Given this list of marker genes ENTPD6, TAF1A, ALG2, TLN2, PECAM1, ICE1, EPPK1, FEZ2, USP19, KANSL2, CYP2E1, ELL, FAM120AOS, IER5, PARP8, CBX4, CPNE7, ZNF263, MLH1 (mutL homolog 1), INPP5B, SLC26A11, TRAF1, TOB2, KBTBD11, PIANP, ARHGEF4, NEURL4, PIM2, MTFR1L, CDH1, UVSSA, SLC9A9, PLP1, IGSF8, PPFIA1, PLXNB2, SGSH (N-sulfoglucosamine sulfohydrolase), EDRF1, PRKCE, CARD6, FOXJ2, TAB2, ZNF623, NR1D2, CLCN6, RNF213, ZSWIM7, OTUD1, TTLL11, BRF1, SOCS7, MNX1, C1orf131, PGS1 (NCBI Gene Id 9489), ZDHHC3, RAB37, CRIM1 (NCBI Gene Id 51232), TNFRSF25, MGRN1, BEND3, POU6F1, PER3, COQ2, RBMS2, DHX33, IKBKE (NCBI Gene Id 9641), CUL9, RTP3, DNAJB2, PHF1, CAMKK1, PIK3R2, SEMA4A, SLC30A1, BRWD1, UBR5, DOLK, ARHGAP31, PPP1R13B (protein phosphatase 1 regulatory subunit 13B), KCNJ8, STAR, RREB1, FARP2, LPIN1, PHF21A, ZNF76, DDX60, DCAF8, ZNF217, UBA7, DBP, SBSN, AMIGO1, PDE4DIP, ZBTB7A, LRIG2, DMRTA1, C19orf48P, JMY, SEC16A, PPCDC, MIGA2, HDAC11, RIGI, CRTAM, ZBTB26, ADCK1, SFI1, RAPGEF2, BTG1, SLC20A1, CASP9, MAN2C1, KMT2C, NSUN4, PLEKHM3, IL7R, SLC35E3, DANCR, HS6ST1, METTL22, PFN2, XCL1, ZNF746, ARRB1, MICALL1, OSM, ZNF318, NMNAT3, DYRK2 (dual specificity tyrosine phosphorylation regulated kinase 2), P2RX4, GUF1, GSDMD, QPRT, ZBTB4, BCL11B, FCGR2B, DGKE, TRMT1, NPEPL1, DDB2, ZCCHC24 (zinc finger CCHC-type containing 24), BCOR, APOBR, ABTB3, LPP-AS2, AIRIM, TCN2, MDN1, TEF, RAB6B, PIK3IP1, GTF3C1, PRAMEF25, JADE2, FAM86B2, ZSCAN26 (NCBI Gene Id 7741), KIF3B, CBX7, GRWD1, HLA-E, SIPA1L3, FBXW4, RPL12, SEMA4B, PANK4, ENDOG, ARF3 (NCBI Gene Id 377), SF3B3, PRSS12, MBOAT7, DVL1, NR4A3, EEF1G, IFT172, AGO1, FBXL17, ZBTB18, RFLNB, BRAP, CYP17A1, SPOUT1 (SPOUT domain containing methyltransferase 1), SUSD2, BBS2, CREBRF, ZNF827, CZIB, FYCO1, NPFF, SGSM2, MAP3K14, JARID2, LEAP2, PRKCA, EHD3, TM6SF1, RERE, ARFRP1 (NCBI Gene Id 149661), TCAIM, PTCH1, here is a description of the gene set: CD8 T cells play a crucial role in immunity to infection and cancer. They are maintained in constant numbers, but upon stimulation with antigen undergo a developmental program characterized by distinct phases encompassing the expansion and then contraction of antigen-specific populations, followed by the persistence of long-lived memory cells. Although this predictable pattern of a CD8 T cell response is well established, the underlying cellular mechanisms regulating the transition to memory remain undefined. Here we show that TRAF6, an adapter protein in the TNF-receptor (TNFR) and IL-1R/TLR superfamily, regulates CD8 T cell memory development following infection by modulating fatty acid metabolism. We show that mice with a T cell-specific deletion of TRAF6 mount robust primary CD8 T cell effector responses, but have a profound defect in their ability to generate memory. This defect is CD8 T cell intrinsic and is characterized by the disappearance of antigen-specific cells in the weeks following primary immunization. Microarray analyses revealed that TRAF6-deficient CD8 T cells from early timepoints following immunization exhibit altered expression of genes that regulate fatty acid metabolism. Consistent with this, activated CD8 T cells lacking TRAF6 are unable to upregulate mitochondrial β-oxidation in response to growth factor withdrawal in vitro. Treatment with drugs that induce fatty acid oxidation enabled CD8 T cell memory generation in the absence of TRAF6. Remarkably, these treatments also increased CD8 T cell memory in wild type mice, and consequently were able to significantly improve the efficacy of an experimental anti-cancer vaccine. from publication Pearce EL, Walsh MC, Cejas PJ, Harms GM, Shen H, Wang LS, Jones RG, Choi Y (PMID 19494812) Human Gene Set: GSE15750_DAY6_VS_DAY10_EFF_CD8_TCELL_DN species: Homo sapiens Genes down-regulated in comparison of wild type CD8 effector T cells at day 6 versus those at day 10.